The following is a description of a gene set: The ovaries analyzed showed a pronounced population of CD53high/CXCR4high immune cells (Fig. 2e), including separate clusters for adaptive T lymphocytes and Natural Killer (NK) cells (CL4 and CL12), B lymphocytes (CL18), and innate immune system, such as monocytes and macrophages (CL13) species: Homo sapiens Human Gene Set: FAN_OVARY_CL18_B_LYMPHOCYTE from publication Fan X, Bialecka M, Moustakas I, Lam E, Torrens-Juaneda V, Borggreven NV, Trouw L, Louwe LA, Pilgram GSK, Mei H, van der Westerlaken L, Chuva de Sousa Lopes SM (PMID 31320652), and this is the list of marker genes: RNF149, VAMP8, PAXX, CYRIB, CCDC50, AP3S1, ISCA1, PABPC1, PSMA5, SELENOT, CTSC, LGMN, TNIP1, IRF4, CXCR4, CREM, CTSS, TUBB6, PLD4, SEC61A1, PRR13, TMEM243, CD4, GNA13, GRSF1, OPN3, LSP1, SIVA1, FERMT3, UBE2A, HEXB, TAGLN2, FKBP2, CLIC3, CCDC12, HCLS1, MAP1A, LAGE3, SPCS1, TUBA4A, IRF8, SMIM14, PHACTR1, DNAJA1, TXNRD1, USP8, AKAP13, MOB1A, RGS2, PTCRA, ARL6IP5, SEC13 (SEC13 homolog, nuclear pore and COPII coat complex component), TOX4, GUK1, MTDH, BID, PKM, HSPD1, ATF5, TYROBP, IK, SELL, HLA-DQB1, ANKRD12, SQSTM1, RELB, MOB4, TYMP, RILPL2, BRD4, NINJ1, RPS26, MKNK2, REL, HSPA1B (NCBI Gene Id 3304), ATP6V1B2, SEC61B, NR3C1, ITM2C, MANF, GNA15, ALKBH5, RPS29, RPN2, TAPBP, H1-2, THEMIS2, IL2RG, N4BP2L1, GNG5, HLA-DQA1, ALOX5AP, HLA-DPA1, ARF6, ISCU, PGK1, UBE2L3 (ubiquitin conjugating enzyme E2 L3), NOP58, CLEC2D, CMTM7, CDC37, HERPUD1, CRIP1, LRRFIP1, IRF7, NUDC, TUBB4B, GPR183, CCR7, GGA2, SRSF3, C12orf75, PFN1, MRPS6, KMT2E, BIRC3, COPB1, LSM1, TSPAN13, SF1, PSENEN (presenilin enhancer, gamma-secretase subunit), MRPL47, ELOF1, UGCG, ELOA, ARFGAP3, DDX39A, HINT1, ARPC4, SSR4 (signal sequence receptor subunit 4), RHOF, SLC7A11, VCP, GRN, HLA-A, GRB2, GOLT1B, NOPCHAP1, CYB561A3, CORO1C, HSPA1A, RPS10, SEC61G, LLPH, AKIRIN2, IDS, TOP1, NFKB2, RBM42, YWHAZ, EIF6, DDX5, TOMM20, SUPT5H, B2M, LITAF, POLE3, CD53, MYBL2, TXN, ARPC5L, ATP1B3, PLEK (pleckstrin), PIM3, CYBA, PSMD14, KPNA2, SH3BP5, TGFBR1, BAZ1A, POLB, CMSS1, TCF25, ZC3HAV1, IL3RA, TACC1, CHCHD10, PLAC8, COX5A, PPP1CB (protein phosphatase 1 catalytic subunit beta), RPL27, MRPL18, ANXA11, PLP2, HSP90B1, CORO1A, SAT1, AKIRIN1, ETF1, EZR, PTP4A2, SMC4, SELENOS, GTF2B (general transcription factor IIB), FTL, MZB1, CST3, TRIB1, SRSF7 (serine and arginine rich splicing factor 7), TXNL4A, CD2BP2, GPX1, IFNGR1, MAP2K3, CD68, SRGN, SCT, RBM3, BLOC1S2, GPR65, DNAJB11, CAPG, SH3BGRL3, RRBP1, RBM5, SIDT1, MAD1L1 (mitotic arrest deficient 1 like 1), LCP1, RPL28, PMEPA1, SRSF2, REPIN1, CMTM6, NCF1, TMEM248, DNASE1L3, RNF145, RANBP2, HVCN1, MS4A6A, VDAC3, NPC2 (NCBI Gene Id 10577), GZMB, NDUFV2, GPSM3 (G protein signaling modulator 3), TM9SF2, HLA-DPB1, SEPTIN6, FKBP4, SLC7A5, SYNGR2, POLR2J3, NAA50, IL4I1, SUB1, SH3TC1, ADRM1, ARPC1B, LILRA4, RAN, SERPINB9, NFKB1 (nuclear factor kappa B subunit 1), TRA2B, ARID5A, SH2B3, RHOG, MBP, TALDO1, RTF2, ERP29, SPON2, TGFB1, SARAF, EGLN3, CD37, CHCHD2, RPS28, MGAT2, TPM3, FXYD5, DDB1, NOP10 (NCBI Gene Id 55505), CD74, CBX6, NOP56, GLIPR1, LDLRAD4, HM13, CD44, HLA-DRA, RAP1A, HSPA4, BZW1, B4GALT1, EIF5A, CD79A, RPL37, YTHDF2, ALG2, HLA-DMA, STK4, FCER1G, CFLAR, JCHAIN, FYTTD1, MIR155HG, SPIB, DHRS7, JAML, SSR3, PTPN1, COX6A1 (cytochrome c oxidase subunit 6A1), SAR1B, TES, CNPY3, DLD, SPCS3, PARK7, RNASET2, UQCR11, SERP1, SEC11C, G3BP2, ARHGDIB, RAB8A (RAB8A, member RAS oncogene family), PRDX1, PHF20L1, PMAIP1, RAB5C, PAK1, ATP6V0E1, LIMD2, DEDD2, LPXN, APRT, DBI, SUPT4H1, DERL3, DDX21, HSPH1, RALA, SNRPG, EMC3, COX4I1, MALT1, SNF8, RHOA, GTF3A, PPP1CA, CDK2AP2, ATP6V0B, RPS11, RNF130, CAP1, PPP1R2, ELF1, PPP1R14B, CAPZA1, RUBCN, HLA-DRB5 (major histocompatibility complex, class II, DR beta 5), ALG13, CACYBP, PSMB4, TNFRSF21 (NCBI Gene Id 51323), UBA52, HSPA8, RPLP2, TRAF4, HCST, ATP6V0D1, PPM1G, EEF1B2, PTGDS, EMP3, ASF1A (anti-silencing function 1A histone chaperone), HSPE1, ZNF706, YPEL5, FABP5, CALR, CD83, H2AZ2, LTB, HLA-DRB1, UCP2, ARPC3, OFD1 (NCBI Gene Id 8481), FAU, HLA-C, ACTN4, CLECL1P, LILRB4, SLC15A4, PAG1, GABARAPL2, CYTIP, ENSA, SLC3A2, PSMB3, TPT1, COPE (NCBI Gene Id 80158), ANKRD11, CDC42SE2, FTH1, P4HB, ACSL3, EVI2B, P2RY6, IGKC, LAPTM5, ARPC2, RPS12, JTB, HES4, ACTR2, PSMC2, DDX24, HLA-DMB, FMNL1, CTSZ, PTPN2, ISG20, ARHGDIA, CTSB, HSP90AA1, TCF4, RBX1, CHORDC1, M6PR, HLA-B (major histocompatibility complex, class I, B), ANP32A, ATP5F1E